The following is a description of a gene set: The chemical reactions and pathways resulting in the breakdown of terpenoids, any member of a class of compounds characterized by an isoprenoid chemical structure. Human Gene Set: GOBP_TERPENOID_CATABOLIC_PROCESS species: Homo sapiens, and this is the list of marker genes: BCO2, AKR1B10, CYP26B1, CYP26A1, CYP2W1, PLPP6, AKR1C3, CYP26C1